Given this list of marker genes Tcf3, Bcl2, Trp53, Prkdc, Slamf8, Rag2, here is a description of the gene set: Mouse Gene Set: GOBP_B_CELL_LINEAGE_COMMITMENT species: Mus musculus The process in which a lymphoid progenitor cell becomes committed to become any type of B cell.